The following is a description of a gene set: An abnormality of the distribution of hair growth that is acquired during the course of life. Acquired abnormal hair pattern Human Gene Set: HP_ACQUIRED_ABNORMAL_HAIR_PATTERN species: Homo sapiens, and this is the list of marker genes: AP2M1, ITGB4, KRT83, IKBKG, CNBP, GJA8, PADI3, ZMPSTE24, HRAS, RNU4-2, ANTXR1, KRT86, EBP, APC, PQBP1, IL2RA (NCBI Gene Id 3559), TP63, SYNGAP1, TRAC, HR, SLC2A1, PORCN, ABCD1, SCN1A, NR3C1, WNT4, KCTD1, LMNA, NECTIN4, NEXMIF, EXOSC2, SLC6A1, KDM5C (lysine demethylase 5C), LAMB3, DMPK, ALMS1, AIRE, TGM3, KRT81, DSG4, GJA5 (NCBI Gene Id 2702), ECM1, COL17A1, ASL, CHD2, BLM